The following is a description of a gene set: studied in species Homo sapiens KSHV vGPCR to GNB/G-PI3K-JNK signaling pathway. Pathway ID: N00178. Pathway type: Pathogen. Pathway class: nt06224 CXCR signaling. Human Gene Set: KEGG_MEDICUS_PATHOGEN_KSHV_VGPCR_TO_GNB_G_PI3K_JNK_SIGNALING_PATHWAY Pathway Definition from KEGG: vGPCR -> GNB/G -> PI3Kgamma -> PREX1 -> RAC1 -> JNK -> NFKB => (IL6,CXCL8), and this is the list of marker genes: PREX1, GNG3, MAPK8, PIK3R5, GNG11, MAPK10, GNB5, CXCL8, GNG4, PIK3R6, GNG12, NFKB1, GNB4, GNB2, GNGT1, GNG2, GNG10, GNG13, GNGT2, GNB3, GNG8, IL6, GNG7, PIK3CG, GNB1, GNG5, RAC1, RELA (NCBI Gene Id 5970), MAPK9